Given this list of marker genes PROK2, PUF60, TDO2, SPRY4, FGF8, IPO8, KIF22, PLOD1, ATP6V0A2, DSE, AP4E1, MSTO1, MED12, FGFR1, TAC3, ATP6V1E1, FGF17, NHLH2, COL5A1 (NCBI Gene Id 1289), MCTP2, TONSL, SATB2, HS6ST1, AP4M1, ATP6V1A, CHST14, COL1A1, AP4S1 (NCBI Gene Id 11154), AEBP1, COL5A2, AP4B1, COL2A1 (collagen type II alpha 1 chain), LONP1, KISS1, FGFR3, WDR11, C1R, COMP, PROKR2, CHD7, KISS1R, PHIP, GNRH1, GNRHR, NSMF, TACR3, DUSP6 (NCBI Gene Id 1848), SERPINH1, here is a description of the gene set: Human Gene Set: HP_GENERALIZED_JOINT_HYPERMOBILITY Joint hypermobility (ability of a joint to move beyond its normal range of motion) affecting many or all joints of the body. In individuals with Joint hypermobility at multiple sites (usually five or more), the term generalized joint hypermobility is preferred. species: Homo sapiens Generalized joint hypermobility